The following is a description of a gene set: Mouse Gene Set: GOBP_TRANSCRIPTION_ELONGATION_BY_RNA_POLYMERASE_I The extension of an RNA molecule after transcription initiation and promoter clearance at an RNA polymerase I specific promoter by the addition of ribonucleotides catalyzed by RNA polymerase I. studied in species Mus musculus, and this is the list of marker genes: Polr1d, Ercc3 (excision repair cross-complementing rodent repair deficiency, complementation group 3), Polr2e, Ercc6, Polr1f (RNA polymerase I subunit F), Ercc2, Gtf2h5, Polr1e, Ubtf